Given this list of marker genes Ankrd52, Caln1, Cldn22, Thra, Aplnr, Tmcc3, Epas1, Cdkn2d, Trabd2b, Dctn1, Tmem222, R3hdml, Ccar2, Emc2, Eif4g2, Bzw2, Mtcl2, Mbd6, Nfam1, Clic5, Zfp703, Fbxo11, Epha4, Eddm3b, Tspoap1, Stac2, Tyk2, here is a description of the gene set: species: Mus musculus from publication Chen Y, Wang X (PMID 31504780) Genes predicted to be targets of miRBase v22 microRNA mmu_miR_6978_5p in miRDB v6.0 with MirTarget v4 prediction scores > 80 (high confidence targets). Mouse Gene Set: MIR_6978_5P